Given this list of marker genes Ints7, Hoxa11os, Pde4d, Crebzf, Pcna, Hoxa7, Zic4 (NCBI Gene Id 22774), Dtl, 9630013D21Rik, AV099323, Tcf4, Vgll3, here is a description of the gene set: Mouse Gene Set: ASH1L_TARGET_GENES from publication Yevshin I, Sharipov R, Kolmykov S, Kondrakhin Y, Kolpakov F (PMID 30445619) Genes containing one or more binding sites for (Ash1l) in their promoter regions (TSS -1000,+100 bp) as identified by GTRD version 20.06 ChIP-seq harmonization. species: Mus musculus